Given this list of marker genes Fbxo43, Lif, Osm, Arhgap33os, Cdca8, Spc25, Incenp, Rad1, Birc5, Fgfr2, Dusp1, Ska3, Rps6ka2 (ribosomal protein S6 kinase, polypeptide 2), Zfy2, Cenpe, Ik, Cep192, Zw10, Haspin, Mad2l1, Cdc20, Fbxo5, Zfp207, Gen1, Bmp7, Hormad1, Bmp4, Psmg2, Fgfr3, Apc, Prpf4b, Plk1, Atm, Nme6, Dmrt1, Bub1b, Zwint, Ttk, Nanos2, Esr1, Ccnb1, Xrcc3, Tom1l1, Ska1, Spc24, Prap1, Cdk5rap2, Khdc3, Chek1, Kntc1, Klhl22, Tpr, Mad2l1bp, Trip13, Usp44, Rad21, Tom1l2 (NCBI Gene Id 72936), Mad1l1, Nuf2, Dync1li1, Ndc80, Ccnb1-ps, Bub3, Lcmt1 (leucine carboxyl methyltransferase 1), Tex14, Pcid2, Anapc15-ps, Spdl1, Knl1, Zwilch, Aurkb, Mtbp, Anapc15, Bub1, here is a description of the gene set: Any process that stops, prevents, or reduces the frequency, rate or extent of nuclear division, the partitioning of the nucleus and its genetic information. species: Mus musculus Mouse Gene Set: GOBP_NEGATIVE_REGULATION_OF_NUCLEAR_DIVISION